The following is a description of a gene set: species: Homo sapiens Human Gene Set: GOBP_TRACHEA_MORPHOGENESIS The process in which a trachea is generated and organized. The trachea is the portion of the airway that attaches to the bronchi as it branches., and this is the list of marker genes: BMP4 (bone morphogenetic protein 4), RSPO2, CTNNB1, MAP2K2, WNT7B, SHH, TGFBR2, MAPK3, HOXA5, MAP2K1, MAPK1